The following is a description of a gene set: Genes in the cancer module 288. studied in species Homo sapiens Human Gene Set: MODULE_288, and this is the list of marker genes: EDNRA, AVPR1A, OXTR (NCBI Gene Id 5021), BDKRB1, TACR3, CX3CR1, CXCR5, TACR2, CCR2, CCR6, CXCL13, CCR5, EDNRB, AGTR1, CCR1, OPRD1, TACR1, OPRK1, TSHR, NPY5R, CCR8, NPY1R, AGTR2, C5AR1, GNRHR, C3AR1, CXCR2, FPR2, ACKR1, CCL13, ATP8A1, GRPR, FPR1 (NCBI Gene Id 2357), CXCR6, BDKRB2, CXCR4, CCR3